The following is a description of a gene set: Human Gene Set: GOMF_FERROUS_IRON_TRANSMEMBRANE_TRANSPORTER_ACTIVITY Enables the transfer of ferrous iron (Fe(II) or Fe2+) ions from one side of a membrane to the other. studied in species Homo sapiens, and this is the list of marker genes: MMGT1, SLC11A2, SLC39A14 (solute carrier family 39 member 14), SLC40A1, SLC25A37, SLC25A28